The following is a description of a gene set: Genes predicted to be targets of miRBase v22 microRNA mmu_miR_7028_5p in miRDB v6.0 with MirTarget v4 prediction scores > 80 (high confidence targets). Mouse Gene Set: MIR_7028_5P from publication Chen Y, Wang X (PMID 31504780) studied in species Mus musculus, and this is the list of marker genes: Nptx1, Znrf1, Thsd4, Pak5, Nkain2, Tspan7, Irgm2, Rgs14, Bpifb9b, Asb8, Csnk1g1, Sh3rf3 (SH3 domain containing ring finger 3), Rac1, Tef, Tmem200b, Vamp2, Cxcl16, Ucp2, 5031439G07Rik, Slc25a14, Pramel21, Dlg2, Naa80, Nck2, Fnip2, Galnt6, Tal2, Efhd2, C1qtnf6, Usp14, Samd4b (NCBI Gene Id 233033), Zhx3, Sdc3, Gnat2, Etv5 (NCBI Gene Id 75752), Mdga1, Bpifb9a, Casp14, Abraxas2, Atf7ip, Pik3c2a, AW551984, Tsc2 (TSC complex subunit 2), Reep3, Zfp821, Sestd1, Kremen1, Cyp26b1, Hs3st3b1, Kcnv2, Slc8a1 (NCBI Gene Id 319418), Flot1, Sae1 (NCBI Gene Id 80447), Vipr2, Rreb1, Sema5b, Mcf2, Nectin1, Clcnka, Trarg1, Pum2, Ppp2r5d, Zfp568, Crbn, Zfp764l1, Tagln, Mllt6, Nck1, Txlna, Unc5b, Jade2, Neu2, Slc25a21, Rfxap, Larp1, Mkx, Gpr25, Fzd4, Gm4847 (predicted gene 4847), BC035044, Polr1f, Chrna3, Serpinb10, Iqsec1, Vtcn1, Ubn1, Cnksr2